Given this list of marker genes Ano6, Clcn1, Clcnkb, Clcnka, Ano1, Clcn3, Tmc4, Clcn5, Clcn4, Clcn6, Clcn2, here is a description of the gene set: Enables the transmembrane transfer of a chloride ion by a voltage-gated channel. A voltage-gated channel is a channel whose open state is dependent on the voltage across the membrane in which it is embedded. Mouse Gene Set: GOMF_VOLTAGE_GATED_CHLORIDE_CHANNEL_ACTIVITY species: Mus musculus